The following is a description of a gene set: Human Gene Set: WP_CANCER_PATHWAYS species: Homo sapiens Cancer pathways, and this is the list of marker genes: FZD6, SOS1, FRAT1, FASLG, PIK3R1, IL5RA, TGFA, IFNA7, PLCG1, RALGDS, NFKB2, IL13RA1, ROCK1, RPS6KB1, CASP8, IL2RA, ITGAV, PTCH2, IL23A, JAG2, KLK3 (NCBI Gene Id 90446), PRKACG, GNG2, WNT10A, PIK3R3, LAMC3, GSTM4, PLCG2, IL12RB1, CXCR4, CXCL12, LPAR3, GSK3B, EGLN1, CRKL, LAMA2 (laminin subunit alpha 2), RPS6KB2, PTEN, MMP3, IFNA13, JUN, CXCL8, MAPK1, GNB4, LAMA4, RELA, CCND1, WNT11, PTGER1, EML4, ESR1, NOTCH2, SP1, FH, NOS2, LPAR6, DAPK1, E2F1, RASSF1, WNT8A, TCF7, VEGFA, FZD9, CALML4, MGST2, RAF1, MSH3, PIK3CB, RALBP1, CUL2, PLD1, LAMB2, IL5, CBL, GNAI2, GSTP1, RAC1, FZD4, GNGT1, ELOC, EPAS1, ERBB2, RAC3, ARHGEF12, SUFU, HEYL, WNT2, CAMK2B, IL15, GNAS, RAC2, DAPK2, RASGRP4, ITGB1, BMP2, CDH1, KEAP1, RPS6KA5 (ribosomal protein S6 kinase A5), FZD2, IFNA4, AXIN2, NCOA1 (nuclear receptor coactivator 1), PRKACB, TCF7L2 (transcription factor 7 like 2), CSF2RB, PMAIP1, FZD3, EGLN3, MAPK8, PLCB2 (NCBI Gene Id 5330), LPAR2, IFNG, CTNNB1, XIAP, IL6R, ADCY1, RXRB, RASGRP2, BRAF, TCF7L1, CDKN2A, LRP5, LRP6, FGFR3, RXRG, BDKRB1, TGFB1, ABL1, CTNNA1, CAMK2D, PLCB1, FOS, EGLN2, LAMA1, CSF2RA, FLT3, IGF1, RAD51, RARB, ADCY2, LAMC2, LPAR5, DVL2, GSTA4, CREBBP, GSTA5 (glutathione S-transferase alpha 5), RARA, ARNT, CKS1B, ADCY9, PRKCA, F2, PIM2, VHL, BCR, IL12A, MAPK9, GSTA1, BAK1, ADCY7, FGFR4, FADD, GSTM3, IL4R, RALB, MAX, GLI1, AR, WNT10B, SMO, COL4A5, CCNE2, ARHGEF11, EP300, FOXO1, GSTO1, PTCH1, APC, LAMA5, GSTT2B, IFNA6, PIK3CA, TPM3, NFE2L2, IL4, CUL1, PLD2, ALK (NCBI Gene Id 238), CTBP1, PGF, KIT, JAK1, TGFBR2, IL6, PLCB4, CSF1R, NCOA4, EDN1 (endothelin 1), DLL3, WNT5B, CDK4, GRB2, MLH1, IFNA14, HES5, CDKN1A, GNG11, CCND2, IFNA5, F2R, FZD1, GNB3, CCNA2, IKBKG, DDB2, GNG3, FZD7, PTK2, CAMK2A, F2RL3, TXNRD3, CCDC42, AKT1, PPARD, E2F2, MAPK10, IL3RA (NCBI Gene Id 8281), BMP4, DLL1, CEBPA, TRAF6 (NCBI Gene Id 7189), MSH2, AGTR1, LAMA3, WNT3A, WNT7A, NQO1, GSTT2, APAF1, IL6ST, BIRC5, CTBP2, FAS, DVL3, WNT8B, SHH, SOS2, RXRA, ETS1, ZBTB16, IGF1R, TGFB2, VEGFB (vascular endothelial growth factor B), BID, GNAI3, EDNRA, BCL2L1, JAK2 (NCBI Gene Id 3717), WNT16, WNT1, NKX3-1, EGFR, MSH6 (mutS homolog 6), FZD10, JAK3, LAMB3, KITLG, GSTA3, LPAR4, CALML5, IKBKB, TRAF1, PLCB3, HEY1, HSP90B1, CDK6, ADCY8, CTNNA3, MST1, ARAF, MAP2K1 (NCBI Gene Id 5604), MMP2, CASP7, HSP90AA1, GADD45A, FGF1, FRAT2, TRAF5, GNG13, ELK1, GNA12, BCL2, ADCY3, FGFR2, RHOA, ELOB, IL12RB2, RASSF5, NFKB1, GNG10, PLEKHG5, RALA, MGST1, SKP2, BIRC3, MITF, WNT3, PIM1, KIF7, HSP90AB1, GNG12, SMAD4, IL7R, GNGT2, COL4A6, PTGS2 (NCBI Gene Id 5743), ITGA2, GNG7, RET, IL7, HMOX1, CASP9, ITGA3, RB1, TRAF3, IGF2, IL2, GSTM1, MECOM, CCNE1, IFNGR2, FLT3LG, LEF1, CAMK2G, CALML3, ADCY6, GNB5, LAMB1, PAX8, IFNAR2, TGFB3, TPR, HRAS, AKT2, NOTCH4, WNT4, MYC, COL4A1, WNT5A, SMAD3, RASGRP1, VEGFC, CYCS, STAT2, GLI3, GNG8, ARHGEF1, CHUK, HDAC1, IFNA2, MMP1, BCL2L11 (BCL2 like 11), GADD45G, IL2RB, TXNRD2, RBX1, SLC2A1, IL15RA (interleukin 15 receptor subunit alpha), TGFBR1, HIF1A, GNA13, GNAI1, COL4A3, FLT4 (fms related receptor tyrosine kinase 4), CDK2, SMAD2, TRAF2, JAG1 (NCBI Gene Id 3715), PDGFA, IL2RG, LPAR1, IFNA17, LAMB4, EDNRB, DAPK3, PDGFB, RASGRP3, TERT, TFG, BRCA2, PTGER2, NOTCH3, CDKN1B, NCOA3, IFNA21, FZD5, WNT2B, IFNA10, APC2, ARNT2, APPL1, GNA11 (G protein subunit alpha 11), ROCK2, IFNA16, BIRC2, TXNRD1, VEGFD, KRAS, MET, CCND3, MAPK3, PRKACA, WNT6, FZD8, NTRK1, NRAS, PPARG, IFNAR1, GNG4, DCC, HGF, CDKN2B, SPI1, WNT7B, COL4A4, SKP1, COL4A2, IFNGR1, CCNA1, MAP2K2, DLL4, HEY2, STAT6, GNAQ, ITGA2B, GSTM5 (NCBI Gene Id 82154), CASP3, BAD, HHIP, GSTO2 (glutathione S-transferase omega 2), AGT, NOTCH1, NFKBIA, HES1, TRAF4, EGF, IL13, FGFR1, IL12B, ZBTB17 (NCBI Gene Id 7709), IFNA1, JUP, AKT3, IFNA8, PIK3R2, GNG5, IL3, RUNX1T1, STAT5A, EPO, RUNX1, PIK3CD, GSTM2, CCDC6, POLK, STAT3, STAT4, PTGER3, CSF3R, STAT1, PTGER4, TP53, STAT5B, PDGFRA (platelet derived growth factor receptor alpha), GLI2, PDGFRB, PRKCB, CALML6, CRK, BDKRB2, AXIN1, MGST3, GSTA2, GNB2, WNT9A, BIRC7, WNT9B, CTNNA2, BAX, MTOR, E2F3, BBC3, LAMC1, GADD45B, ESR2, MDM2, DVL1, FN1, GNB1, ADCY5 (NCBI Gene Id 255218), HDAC2, KNG1, EPOR, ADCY4, ITGA6, PRKCG, PML